Given this list of marker genes CD274, CD74, MDK, SAMSN1, JAK3, RUNX1, CX3CL1, SFTPD, DLG5 (NCBI Gene Id 9231), GLMN, VSIR, MIR27A, PAG1, DAPL1, INPP5D, ADORA2A, UBASH3B, NR1D1, BTLA, LILRB2, TBX21, PDGFRA, CD300LF, IHH, LST1, PGLYRP1, LDLR, SOCS6, VTCN1, FER, CRTAM, RIPOR2, TMEM131L, INHBA, CD300A, THBD, HLA-G, CD80, STAT5A, DLG1, TIGIT, TREM2, SERPINE2, RUNX3, MIR181B1, TNFRSF13B, PKN1, GCLC, HLX, CLEC4G, RABGEF1, ID2, LILRB1, GAL, ADGRF5, TYRO3, GLI3, LOXL3, ENPP3, CASP3, SCGB1A1, AXL, TNFAIP3, CTSG, LGALS9C, IL4R, ADAMTS18, LGALS9B, LGALS1, IRF1, MIR185, ZBTB46, MIR125A, LAG3, MAD1L1, ARG1, FBXO7, SDC4, PLA2G2F, IL20RB, CEBPB, BMP4, PTPN6, GPER1, HAVCR2, LAX1, SPN, NRARP, CLNK, FOXJ1, ANXA1, CD200, DTX1, HLA-E, SCRIB, LRRC32, ZC3H8, TYROBP, PRDX2, TNFAIP8L2, FGR, PDGFB, IL31RA, LRFN5, TNFSF4, IFNA2, NOS3, TARM1, TNFSF18, CD86, PIBF1, NR1H3, CBLB (Cbl proto-oncogene B), GNRH1, PDCD1LG2, PTPN11, MIR130A, PRKAR1A, SOCS5 (suppressor of cytokine signaling 5), IL4I1, PLA2G2A, PLA2G2D, LILRB4, HMGB1, ALOX12, RAG2, ITCH, PARP3, CYGB, PRKG1, LGALS3, FOXP3, VSIG4, CNR2, IDO1, TNFRSF14, RC3H1, ARG2, TAFA3, TSPAN32, SMAD7, FCGR2B (NCBI Gene Id 2213), CSK, SOCS1 (suppressor of cytokine signaling 1), C1QTNF1, RHBDD3, UFL1, ASCL2, BTN2A2, SYT11, HMGB3, DUSP3, FAM76B, LYN, MILR1, CD33, CBFB, IFNB1, ERBB2, IL2, TBC1D10C, PRNP, PDGFA, IL2RA, PGLYRP2, SHH, MERTK, BTK, MIR30B, ATM, PELI1, CR1, CD9, XCL1, CLEC12A, LAPTM5, CEACAM1, DUSP22 (dual specificity phosphatase 22), EMILIN1, PTPRC, TGFB1, TMX1, CST7, TNFRSF21, GPNMB, APOE, FGL2, MNDA, RC3H2, IFNL1, MARCHF7, SOX11, TWSG1, GRN (NCBI Gene Id 2896), ILDR2, PGLYRP3, PAWR, BPI, SFRP1, ZBTB7B, PTPN2, SH2B3, FGL1, HFE, LGALS9, IL10, CD37, ZC3H12A, RASSF5, PLA2G5, CDKN2A, SRC, CD84, MIR181C, MICA, INHA, NDFIP1, FN1, CTLA4, PRKCD, F2, PDCD1, HLA-DRB1, BCL6, BANK1, PTPN22, MIR21, SLC4A2, CD69, here is a description of the gene set: Any process that stops, prevents, or reduces the frequency, rate or extent of cell activation. studied in species Homo sapiens Human Gene Set: GOBP_NEGATIVE_REGULATION_OF_CELL_ACTIVATION